The following is a description of a gene set: Any abnormality of the blood vessels of the conjunctiva. studied in species Homo sapiens Human Gene Set: HP_ABNORMAL_MORPHOLOGY_OF_THE_CONJUNCTIVAL_VASCULATURE Abnormal morphology of the conjunctival vasculature, and this is the list of marker genes: ERCC2, XPA, SASH1, ERCC4, GNAQ, LIG1, PCNA, ATM, XPC, GDF2 (growth differentiation factor 2), RNF168, MANBA (mannosidase beta), ACVRL1 (activin A receptor like type 1), ENG, SMAD4, NBN (nibrin), GLA, DDB2, CTSA, FUCA1, ERCC3, ANO10, MASP1, SETX, NAGA, PEX6, ERCC5